Given this list of marker genes Socs5, Ascl2, Hlx, Irf1, Zfp35, Bcl6 (NCBI Gene Id 12053), Anxa1, here is a description of the gene set: Mouse Gene Set: GOBP_NEGATIVE_REGULATION_OF_T_HELPER_2_CELL_DIFFERENTIATION studied in species Mus musculus Any process that stops, prevents, or reduces the frequency, rate or extent of T-helper 2 cell differentiation.